Given this list of marker genes ENSG00000274276, GMPR2, CYB5R3, CYB5B, CBS, MTARC1, MTARC2, GMPR, MB, NGB, GPHN (NCBI Gene Id 57566), CYGB, NQO2, here is a description of the gene set: Human Gene Set: GOMF_OXIDOREDUCTASE_ACTIVITY_ACTING_ON_OTHER_NITROGENOUS_COMPOUNDS_AS_DONORS studied in species Homo sapiens Catalysis of an oxidation-reduction (redox) reaction in which a nitrogenous group, excluding NH and NH2 groups, acts as a hydrogen or electron donor and reduces a hydrogen or electron acceptor.